Given this list of marker genes Twist1, Insig1, Tgfb1, Msx2, Insig2, Fgfr2, Fgf4, Bmp4, Gli3, here is a description of the gene set: Mouse Gene Set: GOBP_CRANIAL_SUTURE_MORPHOGENESIS The process in which any suture between cranial bones is generated and organized. studied in species Mus musculus